Given this list of marker genes ENTPD1, FLOT1, HCK, SCN5A, LRP6, CLN3, FASLG, TGFBR2, RANGRF, FLOT2, BMPR1A, INSR, PLPP1, MAPK3, PLPP2, LRRK2, ADTRP, EHD2, ATP1A2, CTNNB1, MYOF, MAPK1, DLC1, PTCH1, SELE, CORO1C, NOS1AP, JAK2, SPRED1, CAVIN3, CDH1, EFNA5, GASK1A, PACSIN2, NOS3, CBL, KCNMA1, NOS1, TRPC4, CTNNA1, CAV2, AKAP6, IRS1, FXYD1 (FXYD domain containing ion transport regulator 1), SLC6A3, LRP8, ATP1B1, NEU3, ADCYAP1R1, CD36, KIF18A, CAVIN4, SLC22A6, KCNA5, TFPI, ATP2B4, PLVAP, SCARB1, CDH15, F2R, HDAC6, SMO, CAVIN1, CDH13, ADCY8, LIPE, SRC, BVES, CAVIN2, SMPD2, ADRA1B, EMP2, HTR2A, MLC1, ADRA1A, SLC2A1, SORBS1, PTGIS, CAV3, CAV1, ASAH2, BMPR2, here is a description of the gene set: A membrane raft that forms small pit, depression, or invagination that communicates with the outside of a cell and extends inward, indenting the cytoplasm and the cell membrane. Examples include flask-shaped invaginations of the plasma membrane in adipocytes associated with caveolin proteins, and minute pits or incuppings of the cell membrane formed during pinocytosis. Caveolae may be pinched off to form free vesicles within the cytoplasm. Human Gene Set: GOCC_CAVEOLA studied in species Homo sapiens